Given this list of marker genes SUSD6, LUZP1, CDIN1, ANKRA2, NQO1, GABRA4, NAV1, SRGAP2, GOSR2, RGMB, NOS1, ETV4, MAP3K11, KLHL14, SSR1, TCEA2, KIF21B, RIMS2, RNF19B, ATP2B4, SATB1, FAM78A, NRIP2, SLC10A7, STAB2, ZNF385A, ZNF862, TRIM4, CLIC5, HNRNPR, CHAF1A, AMOT, PARP6, TRIM46, KIAA0513, SMARCD1, TRIM35, LDLRAP1, FAM53A, TENT4A, IKZF1, ACVR2B, COL16A1, MRPL4, VPS39, TRIM26, TSPAN9, ST3GAL5, MORN5, DGKI, LSM12, STK35, PUM2, SDC3, ERG28, RASSF4, TMEM201, SH3GL2, PAX5 (NCBI Gene Id 5079), KCNJ6, SHOC1, SOX10, SCML1, COL5A3, PPM1M, KCNB1 (NCBI Gene Id 3745), CDON (cell adhesion associated, oncogene regulated), PRR32, RAB1B, ANKFY1, HR, ARHGEF6, C17orf67, NOVA2, KCNIP1, AGO1, NFYA, NEUROD4, YTHDF3, SLC6A17, DCX, NOTCH2, HLA-DOB, AIF1L, WDTC1, RHBDL1, MAFG, PIANP, N4BP1, WASF2, CERS3, TLL2, STEAP2, FNDC3B, CBX7, TMEM217, DUSP13A, RTKN, KCNQ3, KBTBD2, FHL1, DGKK, CECR2, USP7, BAZ2A, PRMT6, XYLT1, KCND1, AK3, SLC37A1, REG3G, ADAMTS4, here is a description of the gene set: Human Gene Set: MIR6879_5P studied in species Homo sapiens Genes predicted to be targets of miRBase v22 microRNA hsa-miR-6879-5p in miRDB v6.0 with MirTarget v4 prediction scores > 80 (high confidence targets). from publication Chen Y, Wang X (PMID 31504780)